Given this list of marker genes SEMA3G, KIAA0319, SEMA5A, RNF6, CDH1, NTN1, CDK5, WNT3A, PLXNA3, MAG, CDKL3, SEMA6C, TRIM46, SEMA6D, RTN4R, MT3, BCL11A, MAP2, SLIT1, PTPRS, TNR, ARHGAP4, RTN4, IFRD1, WNT5A, SEMA4F, DIP2B, HDAC6, RYK, NRP1, SEMA3F, DRAXIN, WNT3, here is a description of the gene set: Any process that stops, prevents, or reduces the frequency, rate or extent of axon outgrowth. Human Gene Set: GOBP_NEGATIVE_REGULATION_OF_AXON_EXTENSION studied in species Homo sapiens